Given this list of marker genes STON1, TBC1D5, EPS15, SLC18A3, STON2, AP2M1, BTBD8, AP2A2, AP2A1, SGIP1, AP2S1, AP2B1, here is a description of the gene set: studied in species Homo sapiens A heterotetrameric AP-type membrane coat adaptor complex that consists of alpha, beta2, mu2 and sigma2 subunits, and links clathrin to the membrane surface of a vesicle, and the cargo receptors during receptor/clathrin mediated endocytosis. Vesicles with AP-2-containing coats are normally found primarily near the plasma membrane, on endocytic vesicles. In at least humans, the AP-2 complex can be heterogeneric due to the existence of multiple subunit isoforms encoded by different alpha genes (alphaA and alphaC). Human Gene Set: GOCC_AP_2_ADAPTOR_COMPLEX